Given this list of marker genes BMP2, BHLHA9, NEDD4L, HOXA13 (NCBI Gene Id 3209), TWIST1, RUNX2 (RUNX family transcription factor 2), MED25, FLNA, FIG4, ERF, COL1A1, MED12, PTRH2, HNRNPR, IHH, BMPR1B, CSGALNACT1 (chondroitin sulfate N-acetylgalactosaminyltransferase 1), HOXD13, TBX5, KIF15, RPL10, ANKRD11, FOXP2, TGDS, PLOD3, KNSTRN, GDF5, GPC3, CANT1, MEIS2, GPC4, INTU (inturned planar cell polarity protein), CHSY1, ERI1, PIK3CD, SRCAP, IRX5 (NCBI Gene Id 10265), NSDHL, MYCN, COL2A1, IFT140, OPA3, FGFR2, LFNG, here is a description of the gene set: species: Homo sapiens An anomaly of the second finger, also known as the index finger. Human Gene Set: HP_ABNORMAL_2ND_FINGER_MORPHOLOGY Abnormal 2nd finger morphology